The following is a description of a gene set: species: Mus musculus Mouse Gene Set: GOBP_REGULATION_OF_EXTRACELLULAR_MATRIX_ASSEMBLY Any process that modulates the frequency, rate or extent of extracellular matrix assembly., and this is the list of marker genes: Emilin1, Tgfbr1 (NCBI Gene Id 674605), Notch1, Smad4, Mad2l2, Sox9, Agt, Tie1, Has2, Tgfbr3, Phldb2, Clasp1, Phldb1, Tgfb1, Smad3, Pparg, Rgcc, Clasp2, Dag1, Antxr1